Given this list of marker genes ABCA3, SFTPC, FAM13A, HLA-DPB1, SFTPA1 (NCBI Gene Id 653509), PDCD1, DPP9, COL3A1, MUC5B, ATP11A, NKX2-1, CSF2RA, EIF2AK4, TERT (telomerase reverse transcriptase), CAPNS1, TERC, SFTPA2, BMPR2, SFTPB, SLC34A2, IFIH1, STN1, PARN, CSF2RB, RTEL1, AGR2, DSP, here is a description of the gene set: studied in species Homo sapiens Pulmonary opacity Human Gene Set: HP_PULMONARY_OPACITY Opacity refers to any area that preferentially attenuates the x-ray beam and therefore appears more opaque than the surrounding area. It is a nonspecific term that does not indicate the size or pathologic nature of the abnormality.